Given this list of marker genes CXCL2, RHOD, CYCS, IGFBP3, TBCA, ATP5ME, TP53I11, CSDE1, RPL7A, DAXX, TPR, HLA-DQA1, MARK3, SGCB, EIF4E, TAF1C, LCK, AP3B2, PRDX4, FN1, ARPC1B, OAZ1, NGF, ITGB8 (integrin subunit beta 8), BNIP3L, PRSS23, TAF10, GOLGA4, PDCD5, CTCF, VIM, NDRG1, ALDH3B2, GALNT2, EFNB1, FLOT1, FGFR4, MT1X, COL3A1, CALU, GLRX, CCNL2, UGCG, RHOB (NCBI Gene Id 388), GOLPH3, EIF3L, HGF, SOD1, AKAP12, BEX3, ANXA1, TXNRD2, CCN2, here is a description of the gene set: studied in species Homo sapiens All common up-regulated stress response genes (Human Environmental Stress Response, H-ESR). The accumulation of DNA damage and mutations is considered a major cause of cancer and aging. While it is known that DNA damage can affect changes in gene expression, transcriptional regulation after DNA damage is poorly understood. We characterized the expression of genes in human primary fibroblasts after exposure to three different kinds of cellular stress that introduces DNA damage: 4-nitroquinoline-1-oxide (4NQO), gamma-irradiation, or UV-irradiation. Each type of stress elicited damage specific gene expression changes of up to 10-fold. A total of genes had similar changes in expression of 3-40-fold after all three kinds of stress. We examined transcription in cells from young and old individuals and from patients with Werner syndrome (WS), a segmental progeroid condition with a high incidence of cancer, and found various age-associated transcriptional changes depending upon the type of cellular stress. Compared to young individuals, both WS and old individuals had similarly aberrant transcriptional responses to gamma- and UV-irradiation, suggesting a role for Werner protein in stress-induced gene expression. Our results suggest that aberrant DNA damage-induced gene regulation may contribute to the aging process and the premature aging in WS. from publication Kyng KJ, May A, Stevnsner T, Becker KG, Kølvrå S, Bohr VA (PMID 15897889) Human Gene Set: KYNG_ENVIRONMENTAL_STRESS_RESPONSE_UP